The following is a description of a gene set: studied in species Homo sapiens Any process that stops, prevents, or reduces the frequency, rate or extent of multiplication or reproduction of fibroblast cells. Human Gene Set: GOBP_NEGATIVE_REGULATION_OF_FIBROBLAST_PROLIFERATION, and this is the list of marker genes: BAX, SKI, NLRC3, EMD, NUPR1, LZTS2 (leucine zipper tumor suppressor 2), TP53, GSTP1, DAB2IP, DACH1, CDC73, MED25, C1QL4, CD300A (CD300a molecule), MORC3, TRIM32, FBXO4 (NCBI Gene Id 55087), TP53INP1, PEX2, MIR494, KMT2A (lysine methyltransferase 2A), SOD2, FTH1, NF1, MED31, LTA, IFI30, SFRP1, ING5, PAWR, PARP10, INCA1, MYC, CAV1, B4GALT7